Given this list of marker genes Pink1, Idh2, Ndufb4, Cox7c, Coq7, Cox6b2, Ccnb1-ps, Ndufb1, Iscu, Atpsckmt, mt-Nd5, Coa6, mt-Co3, Uqcrq, Idh1, Uqcc3, Slc25a33, Fh1, Cox8b, Tnf, Cox6c, Cox6b1, Snca, Suclg2, Bid, Uqcrfs1, Oxa1l, Cox4i2 (cytochrome c oxidase subunit 4I2), Cox7a2l, Mtfr2 (NCBI Gene Id 71804), Idh3a, Mir451b, Bdnf, Atp5mf, Ndufa1, Ide, Sdhb, Atp5pf, Ogdh, Ndufb7, Mup4, Sdhc, Pdhb, Cox5a, mt-Atp8, mt-Atp6, Ndufs1, Idh3g, Atp5f1a, Myog, Cs, Mup11, Mup5, mt-Cytb, Tmem135, Nupr1, Ucn, Ndufa12 (NADH:ubiquinone oxidoreductase subunit A12), Uqcr11, Cox10, Fxn, Tefm, Dnajc15, Ndufs7, Aco2, Bcl2l13, Ndufb5, mt-Nd6, Cox6a2, Afg1l, Myc, Cox5b, Atp5po, Uqcrh, Dguok, Bloc1s1, Vcp, Sdha, Cox8a, Mup1, Ndufc2, Ndufb11 (NADH:ubiquinone oxidoreductase subunit B11), Slc25a23, Msh2, Adsl, Mrps36, Mdh1, Ndufa11, Atp5f1c, Macroh2a1, Atp5f1d, Cox8c, Ppif, Ndufs4, Ndufa8, Idh3b, Uqcc2, Cox4i1, Dld (NCBI Gene Id 13382), Atp5f1b, Ndufa10, Cat, Mfn2, Ndufb6, Stoml2, Ndufb2, Atp5me, Cyct, Ndufa2, Dnajc30, Ak4 (NCBI Gene Id 51874), Ndufs3, Atp6-ps, Abcd1, Cox6a1 (cytochrome c oxidase subunit 6A1), mt-Co1, Ndufb10, Uqcrc1 (ubiquinol-cytochrome c reductase core protein 1), Ndufs5, Mir451a, Park7, Atp5pb, Akt1, mt-Nd3, Ndufa13, Col6a1, Cox7b2, Ndufv1, Slc25a51, Cox7a2, Mdh2, Ogdhl, Sirt3, Nipsnap2, Ndufs6, Ccnb1 (cyclin B1), Ndufa5, Cdk1, Rhoa (NCBI Gene Id 51787), Cyc1, mt-Co2, Atp7a, Mup3, Apoc3, Ndufc1, Ndufs8, Ndufv3, Ndufab1, Chchd2, Mtch2, Ndufb9, Suclg1, 4933405O20Rik, Cox7b, Cox7a1, Ndufa3, Uqcr10, Cbfa2t3, Atp5pd, Sdhd, Mlxipl, Pdha1, Ndp, Aco1, Mdh1b, Trpv4, mt-Nd2, Ndufb8, Tafazzin, mt-Nd4, Arl2, Uqcrc2, Ndufa6, Uqcrb, Coq9, 1700066M21Rik, Atp5f1e, Mtfr1, Pdha2, Ndufa7, Ndufa9, Ndufv2, Antkmt, Pde2a, Sdhaf2, Csl, Actn3, Pank2, Atp5if1, Ndufs2, Shmt2, Sucla2, mt-Nd4l (mitochondrially encoded NADH dehydrogenase 4L), Ndufb3, Ndufaf1, Mtfr1l, Dlat, Chchd10, Dlst, Chchd2-ps, mt-Nd1 (mitochondrially encoded NADH dehydrogenase 1), Mup2, Cycs, Nop53, here is a description of the gene set: studied in species Mus musculus The enzymatic release of energy from inorganic and organic compounds (especially carbohydrates and fats) which requires oxygen as the terminal electron acceptor. Mouse Gene Set: GOBP_AEROBIC_RESPIRATION